The following is a description of a gene set: electronically inferred by orthology from the curated human pathway Reactome Pathway: Transcriptional Regulation by MECP2 This event has been computationally inferred from an event that has been demonstrated in another species.<p>The inference is based on the homology mapping from PANTHER. Briefly, reactions for which all involved PhysicalEntities (in input, output and catalyst) have a mapped orthologue/paralogue (for complexes at least 75% of components must have a mapping) are inferred to the other species. part of: Generic Transcription Pathway species: Mus musculus, and this is the list of marker genes: Lbr, Sin3a